Given this list of marker genes Irs1, Grb2 (growth factor receptor bound protein 2), Irs2, here is a description of the gene set: Reactome Pathway: SOS-mediated signalling part of: IRS-mediated signalling studied in species Mus musculus This event has been computationally inferred from an event that has been demonstrated in another species.<p>The inference is based on the homology mapping from PANTHER. Briefly, reactions for which all involved PhysicalEntities (in input, output and catalyst) have a mapped orthologue/paralogue (for complexes at least 75% of components must have a mapping) are inferred to the other species. electronically inferred by orthology from the curated human pathway